The following is a description of a gene set: Any process that stops, prevents, or reduces the frequency, rate, or extent of T cell mediated immunity. Human Gene Set: GOBP_NEGATIVE_REGULATION_OF_T_CELL_MEDIATED_IMMUNITY studied in species Homo sapiens, and this is the list of marker genes: SLAMF1, SMAD7, PDCD1, SPN (NCBI Gene Id 6693), NCKAP1L, IFNB1, FOXP3 (forkhead box P3), LILRB1, UFL1, HLA-F, AHR, USP5, XCL1, KLRD1, PPP3CB, PTPRC, LILRB4, HLA-G (major histocompatibility complex, class I, G), KLRC1, FCGR2B, IL4I1, MAPK3, CEACAM1, CLEC4G, HFE, ARG1, IL7R, TBX21, CD274, CD80, DUSP22, IFNA2, IL20RB